The following is a description of a gene set: Catalysis of the reaction: phosphomyosin + H2O = myosin + phosphate. Human Gene Set: GOMF_MYOSIN_PHOSPHATASE_ACTIVITY studied in species Homo sapiens, and this is the list of marker genes: PPP1R12B, PPP1CB, MYH3, PPP1R12C, DMPK, PPP1R16B, MYH8, MYH6, PPP1R16A, PPP1R12A